The following is a description of a gene set: species: Homo sapiens The chemical reactions and pathways resulting in the formation of sphingomyelin, N-acyl-4-sphingenyl-1-O-phosphorylcholine. Human Gene Set: GOBP_SPHINGOMYELIN_BIOSYNTHETIC_PROCESS, and this is the list of marker genes: OSBP, ABCA8, SAMD8, SPTLC1, VAPA, SGMS1, SPTLC2, ORMDL1, PEMT, ORMDL3, SGMS2